Given this list of marker genes SFTPC, SFTPA1, BMPR2, CSF2RB, SLC34A2, SFTPB, EIF2AK4, here is a description of the gene set: Human Gene Set: HP_PULMONARY_INTERSTITIAL_THICKENING Pulmonary interstitial thickening Pathological thickening of the pulmonary interstitium visualized radiographically and divided into interlobular and intralobular septal thickening. studied in species Homo sapiens